Given this list of marker genes MTTP, PITPNA, PITPNB, TMEM63B, SCP2, PLTP, ABCA3, here is a description of the gene set: Removes phosphatidylcholine from a membrane or a monolayer lipid particle, transports it through the aqueous phase while protected in a hydrophobic pocket, and brings it to an acceptor membrane or lipid particle. species: Homo sapiens Human Gene Set: GOMF_PHOSPHATIDYLCHOLINE_TRANSFER_ACTIVITY